Given this list of marker genes Trp53, Psma6, Tubb3, Psmb7, Psmd2, Psmd3, Tubb1, Tuba3b, Psmb2, Psmc4, Tubb4b, Psma3, Gtse1, Psmb1, Psmb6, Psma4, Tuba1c, Uba52, Psma5, Mapre1, Psmc2, Ubb, Psmd1, Psmd8, Cdkn1a, Psmd7, Psmd14, Psmc3, Tuba3a, Ccnb2, Hsp90ab1, Psmc5, Tuba1b, Tubb4a, Fkbpl, Psma7, Tuba1a, Psmd6, Psmb4, Uba52rt, Psmb3, Psma1, Tubb2b, Tuba8, Psmd13, Tuba4a, Plk1 (polo like kinase 1), Hsp90aa1, Psmc1, Cdk1, Psma2, Rps27a, Psmd12, Psmc6, Adrm1, Tubb6, Ubc, Psmd11, Tubal3, Psmb5, Ccnb1, Tubb2a, here is a description of the gene set: studied in species Mus musculus Mouse Gene Set: REACTOME_THE_ROLE_OF_GTSE1_IN_G2_M_PROGRESSION_AFTER_G2_CHECKPOINT The role of GTSE1 in G2/M progression after G2 checkpoint